Given this list of marker genes CHKA, CSNK2B, SLC44A5, CHAT, CHPT1, PHOSPHO1 (NCBI Gene Id 162466), BCHE, LPIN1, STARD7, ABHD3, SLC44A2, STARD10, CSNK2A2, PCYT1B, SLC44A3, CEPT1, LPIN2, LPIN3, PCYT1A, PCTP, PEMT, SLC44A4, SLC44A1, MFSD2A, LPCAT1, CHKB, ACHE, CSNK2A1, here is a description of the gene set: <i>De novo</i> (Kennedy pathway) synthesis of phosphatidylcholine (PC) involves phosphorylation of choline (Cho) to phosphocholine (PCho) followed by condensing with cytidine triphosphate (CTP) to form CDP-choline (CDP-Cho). Diacylglycerol (DAG) and CDP-ETA together then form PC. Alternatively, PC is formed when phosphatidylethanolamine (PE) is methylated by phosphatidylethanolamine N-methyltransferase (PEMT). studied in species Homo sapiens part of: Glycerophospholipid biosynthesis Reactome Pathway: Synthesis of PC